The following is a description of a gene set: studied in species Homo sapiens from publication Mikhaylova O, Ignacak ML, Barankiewicz TJ, Harbaugh SV, Yi Y, Maxwell PH, Schneider M, Van Geyte K, Carmeliet P, Revelo MP, Wyder M, Greis KD, Meller J, Czyzyk-Krzeska MF (PMID 18285459) Human Gene Set: MIKHAYLOVA_OXIDATIVE_STRESS_RESPONSE_VIA_VHL_DN Proteins significantly repressed by oxidative stress (hydrogen peroxide in 786-O cells (renal clear cell carcinoma, RCC) expressing VHL. Human renal clear cell carcinoma (RCC) is frequently associated with loss of the von Hippel-Lindau (VHL) tumor suppressor (pVHL), which inhibits ubiquitylation and degradation of the alpha subunits of hypoxia-inducible transcription factor. pVHL also ubiquitylates the large subunit of RNA polymerase II, Rpb1, phosphorylated on serine 5 (Ser5) within the C-terminal domain (CTD). A hydroxylated proline 1465 within an LXXLAP motif located N-terminal to the CTD allows the interaction of Rpb1 with pVHL. Here we report that in RCC cells, pVHL regulates expression of Rpb1 and is necessary for low-grade oxidative-stress-induced recruitment of Rpb1 to the DNA-engaged fraction and for its P1465 hydroxylation, phosphorylation, and nondegradative ubiquitylation. Egln-9-type prolyl hydroxylases, PHD1 and PHD2, coimmunoprecipitated with Rpb1 in the chromatin fraction of VHL(+) RCC cells in response to oxidative stress, and PHD1 was necessary for P1465 hydroxylation while PHD2 had an inhibitory effect. P1465 hydroxylation was required for oxidative-stress-induced Ser5 phosphorylation of Rpb1. Importantly, overexpression of wild-type Rpb1 stimulated formation of kidney tumors by VHL(+) cells, and this effect was abolished by P1465A mutation of Rpb1. These data indicate that through this novel pathway involving P1465 hydroxylation and Ser5 phosphorylation of Rbp1, pVHL may regulate tumor growth., and this is the list of marker genes: OAT, HSPB1, AKR1B1, PGAM1, CALU, CTSD